The following is a description of a gene set: Mouse Gene Set: GOBP_CEREBRAL_CORTEX_GABAERGIC_INTERNEURON_DEVELOPMENT species: Mus musculus The process whose specific outcome is the progression of a cerebral cortex GABAergic interneuron over time, from initial commitment to its fate, to the fully functional differentiated cell., and this is the list of marker genes: Drd1, Cntn2, Lhx6, Rac3, Fezf2, Drd2, Arx, Rac1